The following is a description of a gene set: species: Mus musculus Catalysis of an oxidation-reduction (redox) reaction in which the hydrogen donor and acceptor are the same molecule, and no oxidized product appears. Mouse Gene Set: GOMF_INTRAMOLECULAR_OXIDOREDUCTASE_ACTIVITY, and this is the list of marker genes: Hyi, Itgb3, Ptgds, Gsta5, Pdia4, Pdia3, Cyp2s1, Ptges3, Ech1, Hpgds, Ptgis, Ptges2, Ebpl, Qsox1, Eci2, Hsd3b1, Pdia6, Erp27, Gpi1, Idi1, Eci1, Idi2, Creld1, Hsd3b2, Pdia2, Qsox2, Fahd1, Mpi, Tbxas1, Txndc2, Idi1-ps1, Gsta2, Mri1, Hsd3b6, Tmx3, Hsd3b4, Rpia, Ptges, Echs1, Creld2, Gsta13, Txndc5, Gsta1, Ddt, Dct, Ehhadh, Mif, Pdia5, Enox1, Pdilt, Hsd3b3, Hsd3b8, Tmx1, Idi2l, Fahd2a, Tpi1, Hsd3b9, Erp44, Eci3, P4hb, Ptges3-ps, Ebp, Hsd3b5